The following is a description of a gene set: Mouse Gene Set: GOBP_DORSAL_ROOT_GANGLION_DEVELOPMENT studied in species Mus musculus The process whose specific outcome is the progression of a dorsal root ganglion over time, from its formation to the mature structure., and this is the list of marker genes: Unc5c, Pou4f2, Tubb3, Nrp2, Nrp1, Ctnnb1